Given this list of marker genes RAP1A, CRK, SRC, APBB1IP, BCAR1, FGA, VWF, FN1, ITGB3, ITGA2B, TLN1, FGB, FGG, RAP1B, PTK2, here is a description of the gene set: studied in species Homo sapiens p130Cas linkage to MAPK signaling for integrins Human Gene Set: REACTOME_P130CAS_LINKAGE_TO_MAPK_SIGNALING_FOR_INTEGRINS